The following is a description of a gene set: Human Gene Set: GOCC_CALCITONIN_FAMILY_RECEPTOR_COMPLEX A protein complex which is capable of calcitonin family receptor activity. Calcitonin family receptors may form dimers, trimers or tetramers; adrenomedullin and amylin receptors have only been observed as dimers so far. studied in species Homo sapiens, and this is the list of marker genes: CALCR, CALCRL, RAMP3, RAMP2, RAMP1